Given this list of marker genes Epha7, Fgf13, Rgma, Fstl4, Ptprs, Bcl11a, Ulk1, Spart, Ulk2, Ifrd1, here is a description of the gene set: Mouse Gene Set: GOBP_NEGATIVE_REGULATION_OF_COLLATERAL_SPROUTING Any process that stops, prevents, or reduces the frequency, rate or extent of collateral sprouting. studied in species Mus musculus